Given this list of marker genes Pla2g4a, Gpd1, Obp2a, Mbtps2 (membrane-bound transcription factor peptidase, site 2), Myh9, Adcy10, Comt, Mlycd, Wnt4, Ppp1ca, Mlst8, Abcg1, Ghsr, Avp, Ppp4r3a, Prkag3, Irs1, Htr2a, Gdf15, Ins1, Eno1b (NCBI Gene Id 433182), Ppara, Ces1g, Actn3, Tmsb4x, Hif1a, Mlxipl, Ces1c, Ifng, Prxl2c, Nr1h3, Bcl2l1, Bmp6, Qki, Cry1, Rdh19 (NCBI Gene Id 216453), Tcf7l2, Ptgs2, Ppp1r3g, App, Mup5, Kat2a, Tigar, Il1b, Avpr1a, Abcd1, Tnf, Slc25a12, Pfkfb1, Foxo1, Cd74, Phkb, Hnf4a, Src, Apoe, Dab2, Pou1f1, Lhcgr, Hnf1a, Rdh16, Gper1, Dyrk2, Mup1, Irs2, Acsl5, Ptpn2, Pid1, Nr1d1, Zbtb20, Trem2, Mapk1, Gck, Ndufc2, Ces1b, Nr1h4, Star, Wdr5, Hmgb1, Ddb1 (damage specific DNA binding protein 1), Gpld1, Map2k1, Ces1d, Oprm1, Srebf1, Ces1f, Pptc7, Fdps, Cd244a, Paqr3, Snca, Agt, Phkg2 (NCBI Gene Id 68961), Fgf1, Pparg, Igf2, Clybl, Ppard, Apoa5, Rdh10, Ces1e (carboxylesterase 1E), Ces1h, Lpgat1, Rdh16f2, P2ry1, Sirt1, Sorbs1, Vcp, Scap, Gcg, Rdh1, Rdh9, Dgat2, Pth1r, Fabp1, Gpt, Mid1ip1, Uchl1, Slc45a3, Adipoq, Ces1a, Plin5, Adra1b, Ppp2ca, P2ry6, Elovl5, Adora2b, Mas1, Pth, Phkg1, Mtor, Abcd2, Twist1, Apoc2l, Srebf2, P2rx7, Park7, Cyp7a1, Nos3, Ppp1r3b, Prkaca, Gapdhs, Kat2b, Pmaip1, Avpr1b, Igf1, Stat3, Mup3, Rptor (regulatory associated protein of MTOR, complex 1), Epm2aip1, Prkaa1, Cyp2j6, Mup2, Adcyap1r1, Npy1r, Mtln, Ptafr (NCBI Gene Id 636551), Stard4, Nnmt, Rgn (regucalcin), Pla2g3, Prkg2, Mup11, Mlx, Anxa1, Eno1, Sec14l2, Arnt, Dgat1, Nr1h2, Mup4, Plcd1, Ntsr1, Psen1, Gpi1, Esrrb, Supt20, Myc (NCBI Gene Id 17869), Cpt1a, Arpp19, Akt1, Scp2, Akt2, Prkag2, Nucb2, Prkag1, Sirt7, Ppp4r3b, Ppp1r3e (protein phosphatase 1, regulatory subunit 3E), Ins2, Gnai1, Il4, Mapk9, Phka1, Klhl25, Prkaa2, Apoc2, Sik2, Slc4a4, C1qtnf2, Insr, Por, Prkn, Apoa4, Bend3, Stk11, Sirt2, Apoa1 (apolipoprotein A-I), Abcg4, Ppargc1a, here is a description of the gene set: Any process that activates or increases the frequency, rate or extent of a small molecule metabolic process. Mouse Gene Set: GOBP_POSITIVE_REGULATION_OF_SMALL_MOLECULE_METABOLIC_PROCESS species: Mus musculus